The following is a description of a gene set: Human Gene Set: GOBP_ERK1_AND_ERK2_CASCADE species: Homo sapiens A MAPK cascade containing at least the ERK1 or ERK2 MAP kinases. It starts with the activation of a MAP3K, and the consecutive activation of a MPK2K and of ERK1 or ERK2. The cascade can also contain an additional tier: the upstream MAP4K. The kinases in each tier phosphorylate and activate the kinase in the downstream tier. The ERK1/ERK2 cascade is activated by mitogens, growth factors, G protein-coupled receptors, and results in cellular responses such as cell proliferation, cell differentiation and development., and this is the list of marker genes: GRB10 (growth factor receptor bound protein 10), TBC1D10C, NOTCH2, MIR424, PRKCZ, MT3 (NCBI Gene Id 4504), FGF18, FGG, VEGFB, HCRTR1, FLT4 (NCBI Gene Id 7909), FGF1, RAP1B, PDGFB, FGFR2, ZFP36L1, SIRT3, FGB, CAVIN3, GLIPR2, DRD2, CEACAM1, TRAF7, IQGAP3, TRPV4, FGF23, ARHGEF5, PTPN22, GPER1, FSHR, FGF8, MAP2K7, EPO, MIR221, MIR145, CHRNA9, RASGRP1, JUN (Jun proto-oncogene, AP-1 transcription factor subunit), MIR23A, ARRB1, ITGAV, CD74, XBP1, HTR2B, PIN1, CRKL, GPNMB, TNFSF11, EZR, CSF1R, NRP1, ICAM1, F2RL1, GPR183, NAMPT, TLR9, HTR2C (5-hydroxytryptamine receptor 2C), WNK4, PRKCA, PSCA, SYNJ2BP, MIR503, BRAF, NTRK1, HAVCR2, IL1B, FERMT2, NGF, RIPK2, GAREM1, DAB2, NPY5R, PDE8A, CCN2, MYC, ERRFI1, SPRED1, SRC, PHB2, SYT14P1, TNFRSF11A, OR2AT4, P2RY1, CTSH, FGF4, PDGFRB, YWHAZ, TGFB1, ANGPT1, NPNT, MAP2K1, CSK, SOX9 (NCBI Gene Id 6662), RRAS, MIR205, CXCL17, MIR138-1, SMAD4, ALOX15, PTPN2, DUSP3, BMPER, GPBAR1 (NCBI Gene Id 151306), CX3CL1, CD36, FBLN1, TNIP1, CARD9, BTN2A2, DAB2IP, PLA2G5, CCL21, INPPL1, TNF, GPR55, MAP3K12, CCR7, CDK1, EPHA4, AGER, SEMA7A, NDRG4, KLF4, FGFR3, ADIPOQ, MIR126, EGFR, FGF20 (fibroblast growth factor 20), PTPN6, FFAR4, SLAMF1, PTGER4, NODAL (NCBI Gene Id 8114), EPHB1, APIP, CASR, CD44, RAP1A, FN1, EGF, SEMA6A, ACTA2, IL26, KDR, DUSP29, VEGFA, LGALS9, DDR2, MOS, DUSP26, LIF, RAPGEF2, NRXN1, SPRY3, GCG, NOX4, SPRED3, C3orf33, FAM83D, KARS1, ARRB2, HRAS, DUSP5, DUSP9, PDGFD (NCBI Gene Id 80310), SYK, CHRNA10, MIF, EIF3A (NCBI Gene Id 8661), C1QL4, TREM2, SCIMP, FBXO21, ITGB1BP1, NECAB2, GSTP1, NOD1, BMP2 (NCBI Gene Id 650), PLA2G2A (phospholipase A2 group IIA), RGS14, FAM3C, ATF3, FGF19, DUSP15, PTPN11, ZFP36L2, EPHA7, GBP1 (guanylate binding protein 1), RAMP3, MAPK1, NHERF1, ACE2, DUSP10, MIR200C, CRYBA1, TNFAIP8L3, PDGFA, PTPN1, NF1, MTURN, HESX1, PRXL2C, DUSP7, GAS6, DUSP6, MARCO, SERPINF2, ERBB4, SHC1, RANBP9, PTPRC, MIR27B, ADRA1A, NOD2, SIRPA, F2R, CHRNA7, ADCYAP1, FLCN, CHI3L1, TIRAP (NCBI Gene Id 115469), FGF2, NPSR1, MIR21, ACKR3, FGF10, FGF21, CD2AP, HMGB1, MIRLET7B, NELFE, PTPRR, MFHAS1, DNAJC27, ABL1, ARHGAP8, SPRED2, CNKSR3, SPRY2, FGA, INHBA, TGFBR3, DBNDD2, DDT, S100A7 (NCBI Gene Id 6278), PHB1, PDE8B (phosphodiesterase 8B), APOE (NCBI Gene Id 99), MAP2K2, NEK10, PRMT5, LMO3, MIR27A, RPS6KA6, BMP4, SLC30A10, SPRY4, CCL11, MIR133A1, LYN, NDRG2, PRKD2, DENND2B, IL1A, MIR24-1, MIR133B, NLRP6, OPRM1, PTK2B, ALKAL2, CCL19, EDN1, CCN1, WNK2, CCR1 (C-C motif chemokine receptor 1), SPRY1, P2RY6, PKHD1, ADORA2A (NCBI Gene Id 135), APOA1, IAPP, PDGFRA, HLA-DRB1, HTR2A, C5AR1, FPR2, APELA, NLRP12, ABCA7, FBXW7, TLR4, MIR185, MIR519D, PDGFC, FGFR4, TPBG, ZDHHC17, NRG1, DSTYK, CALCR, EMILIN1, DUSP4, EPHA2, TEK, PYCARD, ITGB3, CD4, CCL3, STYX, EPHB2, ALKAL1, FRS2, AKAP12, ROS1, VRK3, DLG1, MAPK3, GCNT2, HAND2, GNAI2, APP, NOTCH1, CIB1, DUSP1, IGF1, THPO, NPY, ERBB2, HMGCR, CFLAR